Given this list of marker genes KAT6B, WASHC5, LRPPRC, NFIX, PIGN, SLC25A24, TBX3 (T-box transcription factor 3), GRIP1, DYNC2I2, MED12, FGF8, MAB21L1, RNU12, GDF3, ESCO2, FRAS1, PIGY, KYNU, CDON, DDB1, DACT1, PIGL, SHH, SETBP1, MKKS, TGIF1 (TGFB induced factor homeobox 1), DCHS1, NDUFB11, C2CD3, KDM6A, NXN, CDK8, POR, PIGO, GLI2, RECQL4, SALL1, TP63, PIGV, UBR1, FOXH1, PGAP2, FGFR2, KMT2D, RRAS2, NODAL (nodal growth differentiation factor), DYNC2I1, FREM1, FREM2, DPYSL5, PGAP3, HES7, FAT4, CDC45, ACADVL, RFX6, COX7B, DDX6, SIX3, ATN1, B3GLCT, SNRPB, GAS1, FLI1, PIGW, DISP1, STIL, TWIST2, CCDC22, VPS35L, NIPBL, DLL1, GLI3, CHD4, HCCS, WDR35, ZIC3, ROR2, ERCC4, PORCN, SUZ12, IFT80, CDH11, DDX3X, GDF6, DVL3 (dishevelled segment polarity protein 3), DYNC2H1, ROBO1, PTCH1, PTDSS1, MEOX1, MID1, CRIPTO, ZIC2, here is a description of the gene set: Human Gene Set: HP_ECTOPIC_ANUS Abnormal displacement or malposition of the anus. Ectopic anus studied in species Homo sapiens